Given this list of marker genes MIR181A2, FERMT2, TGFBR1, MIR29B1, TGFB1, SIX2, CITED1, VEGFC, LTBP3, MIR16-1, CCNE1, NDUFS6, here is a description of the gene set: Human Gene Set: GOBP_MESENCHYMAL_STEM_CELL_PROLIFERATION species: Homo sapiens The multiplication or reproduction of mesenchymal stem cells, resulting in the expansion of a stem cell population. A mesenchymal stem cell, or MSC, is a cell that retains the ability to divide and proliferate throughout life to provide progenitor cells that can differentiate into specialized mesenchymal cells.